Given this list of marker genes Ndufab1, Ctu1, Fxn, Nfs1, Mocs2, Iscu, Lyrm4, here is a description of the gene set: species: Mus musculus A protein complex capable of catalyzing the transfer of sulfur atoms from one compound (donor) to another (acceptor). Mouse Gene Set: GOCC_SULFURTRANSFERASE_COMPLEX